The following is a description of a gene set: Neighborhood of RAB1A RAB1A, member RAS oncogene family in the MORF expression compendium Neighborhood of RAB1A Human Gene Set: MORF_RAB1A species: Homo sapiens, and this is the list of marker genes: KDM2A, FAM89B, C1D (NCBI Gene Id 10438), TERF2IP, CANX, ZZZ3, SSR1, ARFGAP2, PIGC, VGLL4, RTCB, RAD23B, SUMO2, CAPZB, MKRN1, PUF60, ATP6V1F (ATPase H+ transporting V1 subunit F), TAF9, PMM2, CUX1, UBXN4, SHMT1, ATP6V0D1, HADHB, BECN1, XPO6, ETF1, SDHC, COX4I1, CIB1, NUBP1, RAB5A, COPS5, ATOX1, BCAP31, TIAL1, PSMB4, ENSA, RPN2, ATG9A, PWP1, RAE1, TMSB10, AP2M1, EBAG9, TMEM59, ARFGEF1 (NCBI Gene Id 25860), PHF3, ARCN1, RABAC1, RAB5B, PRKAR1A, CDK16, SUMO3, BLOC1S1, SLC9A1, ESS2, MRPL28, RBCK1, CTDNEP1, PEX11B, VAMP3, PICALM, MEA1, MYL11, COX6A1, RAB1A, CALM2, ACTN4, ARPC4 (actin related protein 2/3 complex subunit 4), PRKCSH, TMBIM6 (transmembrane BAX inhibitor motif containing 6), GMFB, PPP1R7, STK19, PSMB6, PRPF4, CENPB, RNF103, SUMO1, XPC, CNBP, POR, COPB2, PPP2R5E, COIL, ZC3H3, UBE2A, NELFB, DYNC1I2, SEC61G, DCTN2, KDELR1, WBP2, CLTC, PTPN1, COX8A, ZNHIT1, DDB1, NUP62, MDH1, POLR2A, SEC22B (NCBI Gene Id 9554), TOR1AIP1, PGK1, COPS6, CSNK1G2, RTN4, MARCHF7, BRD3, PSMC2, KARS1, SMAD2, SSR2 (signal sequence receptor subunit 2), GANAB, TPR (NCBI Gene Id 7175), COX7A2L (NCBI Gene Id 9167), IST1, RPL36AL, METAP1, MORF4L2, TADA3, COX5B, GPAA1, B4GALT3, LAMP2, AP3S1, ATP6AP2, CNIH1, RPRD2 (regulation of nuclear pre-mRNA domain containing 2), ILVBL, OTUB1, MRPL9, RAD21, DNPEP, DRG1, HUWE1, RAF1, PDAP1, JTB, HTATSF1, UBE2E3, DPM1, ATXN2, VPS9D1, P4HB, ARPC5, RAB6A, ABR, CSNK1D, PRKAG1, RAC1, ILF2, RXRA, TMED2, UBR5, YWHAB, GAA, ZFTRAF1, GORASP2, MORC3, CAPZA1, SLC4A2, CLN3, DUSP11, RHEB, ARF5, DHRS1 (dehydrogenase/reductase 1), SERP1, AREL1, PPP1R11, SLC25A36, ARF4, BZW1, SEC61B, FBXW11, KHDRBS1, ARF3, UBA1, LEPR, SEPHS2, CNOT3, EIF2B2, PPP2R1A, STX4, ZNF410, YWHAZ, GLG1, GFUS, SMNDC1, LASP1, SPCS2, CLEC18C